Given this list of marker genes Adora1, Scn1a, Ap2b1, Drd1, Kcnj6 (potassium inwardly-rectifying channel, subfamily J, member 6), Grik2, Psen2, Drd2, Grik4, Efnb3, Lrrc4b, Efnb1, Cdh2, Itga3, Epn1, P2ry4, Ap2s1, Znrf2, Ptprs, Podxl, Drd4, Gabrb2, Lpar1, Gripap1, Afdn, Htr3a, Kcnh1, Ache, Rgs9, Erc2, Ntng2, Marcks, Apba1, Dnajc6, Cntnap4, Slc1a6, Grm1, Ctnna2, Cnr1, Cacna1e, Stx2, Ryk, Psenen, Ctnnb1, Syt11, Slc6a9, Cltc, Chrm2, C1qa, Ap2m1, Unc13c, Unc13b, Syt7, Exoc3, Otof, Dennd1a (DENN domain containing 1A), Adgrl1, Apbb1, Rgs7 (regulator of G protein signaling 7), Npy1r, Grm8, Kcnc3, Flot2, Ephb2, Cacna1d, Dnm1, Gnb5, Lrfn3, Rims3, Itsn1, Htr1a, Fzd3, Gpr151, Slc4a8, Grm2, Cadm1, Glra1, Atp2b2, Fcho2, Adam11, Erbb2, Tenm3, Cacna2d3, Ctbp1, Efnb2, Scn11a, Gabbr1, Pip5k1c (phosphatidylinositol-4-phosphate 5-kinase, type 1 gamma), Htr2a (5-hydroxytryptamine (serotonin) receptor 2A), Scrib, Pde2a, Fbxo45, Oprk1, Il31ra, Stxbp1, Adcy8, Snap91, Adora2a, Phb1, Slc1a2, Cadps2, Scn10a, Grm3, Kctd8, Chrm1, Gnao1, P2rx1, Gpc4, Scn8a, Gria3, P2rx2, Lpar2, Adra2a, Grin3b, Cacna1h, Chrna7, Ano2, Napa, Kcna2, Dnm1l, Rims2, Pick1, Nrxn2, Dgki, Kcnc2, Kcna4, Cntn1, Atp2b1, Grik1, Cltb, P2ry2, Ncstn, Syp, Gabra6, Cntn5, Kctd16, Gpm6a, Grm4, Marcksl1, Ppfia2, Nrg1, Grin2d, Snap25, L1cam, Itsn2, Napepld, Oprm1, Chrna6, Slc6a4, Slc6a1, Ptprd, Dlg1 (discs large MAGUK scaffold protein 1), Slc6a3, Rgs7bp, Kcnq5, Kcnj11, Flrt2, Gabrr1, Unc13a, Cacna2d1, Ano1, Atp2b4, Hcn1, Adora3, Grin2a (NCBI Gene Id 14811), Casr, Pcdh8, Htr7, C1qc, Slc6a11, Gabra2, Zdhhc17, Gabra5, Grin2b, Septin3, Gabbr2, Slc22a2, Aph1a, Cacna1a, Canx, Septin7, Atp2b3, Scn2a, Cntnap2, Gpr158, Slc1a7, Psen1, Slc6a5, Cacna1c, Kcnma1, Adam23, Gper1, Picalm, Cacna2d2, Grik5 (glutamate receptor, ionotropic, kainate 5 (gamma 2)), Cntn6, Gabra3, Nectin1, Ncam1, Vdac1, Gria4, Stx1a, Fxyd6, Chrnb2, Chrm3, Slc5a7, Cxadr, Igsf21, Snph, Grip1, Kcnj9, Fmr1, Chrna4 (NCBI Gene Id 11438), Pcdh17, Stxbp5, Ngfr, Grin1, Stx1b, Slc6a2, Rims1, Celsr3, Kcnc1, Gad2, Atp1a3, Hip1, Grik3 (glutamate receptor, ionotropic, kainate 3), Htr1b, Mpp4, Glra3, Rab3gap2, Pi4k2a, Nrxn3 (neurexin III), P2rx3 (NCBI Gene Id 78804), Gria2, Erbb4, P2ry1, Slc6a7, Kctd12b (NCBI Gene Id 78453), Kcnj3, Cadm3, Stx19, Gria1, Cyth1, Syap1, Nlgn2, Epha4, Prrt2, Kcnc4 (NCBI Gene Id 99738), Napb, Cdh10, Adra1a, Cplx3, C1qb, Clta, Cask (calcium/calmodulin dependent serine protein kinase), Nptn, Nrxn1, Gabrb1, Ntng1, Cdh9, Kctd12, Kcna3, Fosl1, Chrm4, Kcnj8, Syt1, Grm7, Stx11, Oprd1, Rac1, Kcna1, here is a description of the gene set: Mouse Gene Set: GOCC_PRESYNAPTIC_MEMBRANE studied in species Mus musculus A specialized area of membrane of the axon terminal that faces the plasma membrane of the neuron or muscle fiber with which the axon terminal establishes a synaptic junction; many synaptic junctions exhibit structural presynaptic characteristics, such as conical, electron-dense internal protrusions, that distinguish it from the remainder of the axon plasma membrane.